Given this list of marker genes PEMT, CHPT1, CRLS1, AGPAT4, PCYT2, PNPLA3, CDS1, PTDSS2, PLA2G1B, PLD1 (phospholipase D1), GPAT4, CHKB, GPAM, PNPLA2, DGAT1, ETNK1, PISD (phosphatidylserine decarboxylase), PCYT1A, PTDSS1, DGAT2, DGKZ, CDIPT (NCBI Gene Id 10423), here is a description of the gene set: Glycerolipids and glycerophospholipids studied in species Homo sapiens Human Gene Set: WP_GLYCEROLIPIDS_AND_GLYCEROPHOSPHOLIPIDS